The following is a description of a gene set: Any process that modulates the frequency, rate or extent of glia cell differentiation. studied in species Mus musculus Mouse Gene Set: GOBP_REGULATION_OF_GLIAL_CELL_DIFFERENTIATION, and this is the list of marker genes: Actr3, Bmp2, Il6st, Tgfb1, Zfp365, Egr2, Dicer1, Id4, Epha4, Hdac2, Tlr2 (toll-like receptor 2), Opalin, Mecp2, Bmp4, Bin1, Tnfrsf1b, Mag, Enpp2, Trem2, Id2, Olig2, Serpine2 (serine (or cysteine) peptidase inhibitor, clade E, member 2), Spint1, Hmga2, Prpf19, Dll3, Nr2e1, Prmt5, Dab1, Rtn4, Tnfrsf21, Ptprz1, Ldlr, Mbd1, Dusp15, Il34, Dlx1, Lin28a, Hes5, Trp73, Qki, Mycn, Rheb, Casz1, Pparg, Ctnnb1, Fgfr3, Hdac1, Lif, Mir23a, Cxcr4, Nf1, Rela, Ntrk3, Nr1d1, Mdk, Nkx6-2, Aspa, Wdr1, Myrf, Nkx2-2os, Mir219a-1 (NCBI Gene Id 723823), F2, Dag1, Bag1, Il33, Tmem98, Nkx6-1, Il1b, Notch1, Zfp488, Sirt2, Mir219a-2, Cntn2, Gpr37l1, Nog, Shh (sonic hedgehog), Tenm4, Sox1, Ptn, Rnf112, Hes1 (hes family bHLH transcription factor 1), Mtor, Kdm4a, Nkx2-2, Slc45a3, Atf5, Daam2, Lingo1, Tcf7l2, Csf1r, Ptpra, Clcf1, Gsx2, Dlx2, Clcn2, Dusp10, Ntf3, Drd3